Given this list of marker genes SELENOK, CORO1A, PLA2G7, STK39, MSTN, SERPINE1, FADD, HMGB1, ASCL2, TMEM102, ABL2, OXSR1, CCR2, PTPRJ, NEDD9, CCL4, CCR6, P2RX4, C5AR1, DOCK8, CCL3, S100A7, AKIRIN1, C3AR1 (NCBI Gene Id 719), ITGA4, P2RY12, ADAM8, IL34, MED23, CREB3, TNF, CD99L2, ADAM17, MADCAM1, DEFB131A, JAM3, CMKLR1 (chemerin chemokine-like receptor 1), TGFB1, SPN, WNT5A, LGMN, FPR2, ANO6, P4HB, JAM2 (junctional adhesion molecule 2), CCR7, TNFRSF14, CD47, XCL1, CCL2, MAPK3, CCL21, CCR1 (C-C motif chemokine receptor 1), ADAM10, SLAMF1, TNFSF18, CCL20, CSF1, CXCL13, GAS6, C1QBP, MMP14, TNFSF14, ITGB3, RHOA, PYCARD, LGALS3, TREM2, SPI1, AIF1, CXCL10, RARRES2, S100A14, CXCL12, PTK2, PTK2B, MOSPD2, RTN4, CX3CL1, CSF1R, THBS1, AGER, DEFB124, CCL5, CXCL17, PDGFD, LGALS9 (galectin 9), CALR (NCBI Gene Id 811), APP, WNK1, MAPK1, ABL1, CX3CR1 (C-X3-C motif chemokine receptor 1), CCL1, TRPV4, IL12A, CCL7, MDK, here is a description of the gene set: species: Homo sapiens Human Gene Set: GOBP_POSITIVE_REGULATION_OF_MONONUCLEAR_CELL_MIGRATION Any process that increases the rate, frequency or extent of mononuclear cell migration. Mononuclear cell migration is the movement of a mononuclear cell within or between different tissues and organs of the body.